The following is a description of a gene set: Genes predicted to be targets of miRBase v22 microRNA hsa-miR-6832-5p in miRDB v6.0 with MirTarget v4 prediction scores > 80 (high confidence targets). Human Gene Set: MIR6832_5P studied in species Homo sapiens from publication Chen Y, Wang X (PMID 31504780), and this is the list of marker genes: COPS2, AHCYL2, KIAA1958, SLC36A3, HTRA3, ZNF484, SEMA3E, KPNA2, CLEC2B, N4BP2, GYPB, FAM120A, CAMTA1, ADAM12 (ADAM metallopeptidase domain 12), AK5, NPHP3, CCDC28A-AS1, COBLL1, PTPN4, CNOT8, FAM227A, ABCC9, AAK1, CSMD3, RNLS, NBPF15, NBPF14, TRIM22, VSTM2A, VPS26A, PAQR9, DDX5, KLHL29, ANXA7, TMPRSS11B, PDK4, RABGAP1L, LOXL1, GJA5, ST8SIA1, UGGT1, NBPF20, CCSER1, SRGAP3, CCDC39, CDK4, LAMC1, KRTAP9-8, KLHL24, PRRC1, LRRTM3, GJC1, PDPK1, STAM2, ABR, NAPEPLD, CYP20A1, MTCL2, GDNF, GZF1, B3GAT2, PITPNC1, SLC20A1, NBPF8, EGLN1, PDHA1, RAD51B (RAD51 paralog B), ANKRD34C, RTL9, LY6D, CDK5RAP3, NMBR, SYNC, THPO, UACA, PDE6H, PTPRK, KAT2B, LPP, KRTAP9-2, PIK3C2A, CGGBP1, ZIK1, GYPE, KRTAP9-3